The following is a description of a gene set: Pathway Definition from KEGG: Glycogen -- (PYG+AGL) >> PGM1/2 -> Glc-6P -- G6PC1/2/3 -> Glc Human Gene Set: KEGG_MEDICUS_REFERENCE_GLYCOGEN_DEGRADATION Glycogen degradation. Pathway ID: N00718. Pathway type: Reference. Pathway class: nt06017 Glycogen metabolism. studied in species Homo sapiens, and this is the list of marker genes: PYGB, AGL, G6PC2, PGM2, PYGL, G6PC1, PGM1, G6PC3, PYGM